Given this list of marker genes ITGB3, CRK, FBN1, SYAP1, GHSR, SLC25A33, CFL1, TGFB1, CACNA2D3, CCNA2, CREB1, IGF1, here is a description of the gene set: Any process that results in a change in state or activity of a cell (in terms of movement, secretion, enzyme production, gene expression, etc.) as a result of an insulin-like growth factor stimulus. studied in species Homo sapiens Human Gene Set: GOBP_CELLULAR_RESPONSE_TO_INSULIN_LIKE_GROWTH_FACTOR_STIMULUS